Given this list of marker genes PITPNM2, VAMP2, DIXDC1, NR3C2, SYT1, WDR37, NSA2, ATAD1, DTNA, ELOVL6, OTUD4, AKR1C2, ARHGAP11A, SLC16A6 (solute carrier family 16 member 6), KCNJ15, EDEM3, ERV3-1, ZNF131, SLC30A4, C2CD2, EBF1, MAPK1, DESI1, MYRIP, DCUN1D4, IKZF3, STK38, RIMS2, INAFM2, RAD51B, BOLA2-SMG1P6, NTNG1, G3BP1, CDYL2, LMX1B, CACNA1D, CLVS2, CTTNBP2, PDS5B, KCNB1, SPATA2, YWHAG, IGLON5, ZNF518A, ROCK2, SETD9, WFDC13, ACSL4, RARB, FCHO2, ENOSF1, HECTD2, CNIH1, PLCXD3, PRRC2C, PIK3CD, POLR3C, CSN3, ROBO1, ATP2B4, SS18, KCNS3, ZRANB1, KLF13, CPLX1, PHF13, ATXN7L1, CARHSP1, PDE1C, MBNL2, DAG1, TMEM104, RYBP, SGMS1, PHLDB2, KCNAB3, LZTS1, KALRN, UTRN, SLC24A2, KCNQ5, RBAK, TRIL, NCOA1, RB1CC1, EHHADH, SEC14L1, MTMR2, SCGB2B2, AGO3, SV2B, ZNF704, KRT20, CHD1, SMIM13 (NCBI Gene Id 221710), ESRRG, RALBP1 (NCBI Gene Id 10928), KAT6A, UBE2D3, MDH1B, RPL36A, KHDRBS3, XRCC2, XYLT2, CDV3, PPP6R3, HDAC1, DPH5, RUNX2, MFHAS1, MYL12A, SSR2, TOMM22, ZCCHC7, here is a description of the gene set: from publication Chen Y, Wang X (PMID 31504780) species: Homo sapiens Human Gene Set: MIR889_5P Genes predicted to be targets of miRBase v22 microRNA hsa-miR-889-5p in miRDB v6.0 with MirTarget v4 prediction scores > 80 (high confidence targets).